The following is a description of a gene set: The series of molecular signals initiated by an extracellular ligand binding to a transforming growth factor beta receptor on the surface of a target cell, and ending with the regulation of a downstream cellular process, e.g. transcription. Mouse Gene Set: GOBP_TRANSFORMING_GROWTH_FACTOR_BETA_RECEPTOR_SIGNALING_PATHWAY species: Mus musculus, and this is the list of marker genes: Npnt, Peg10, Ptk2, Mir145b, Ero1a, Rnf111, Bcl9l, Tgfbr1, Bambi, Mstn, Skil, Trim33, Smad2, Htra3, Selenon, Cited1, Lrrc32, Snx1, Sox11, Smurf1, Skor2, Ppara (peroxisome proliferator activated receptor alpha), Onecut1, Pin1, Slc2a10, Itgb5, Zmiz1, Foxh1, Cldn5, Arrb2, Dnm2, Wfikkn2, Cidea, Pin1rt1, Fos, Acvrl1, Adissp, Lats2, Twsg1, Zfp451, Zyx, Tnrc6c, Fbn1, Gdf2, Parp1, Lats1, Dand5, Fbn2, Sirt1, Map3k1, Ryr1, Ltbp1, Sap130, Cdh3, Snw1, Mir143, Pxn, Ing2, Snx6, Brms1, Tgfb1i1, Arap1, Gcnt2, Pbld1, Amhr2, Wfikkn1, Nrep, Myocd, Lox, Emilin1, Col1a2, Fermt2, Furin, Bmp2, Hspa5, Adam17, Stk11, Smad5, Ovol2, Bmpr1a, Stat3, Hpgd, Strap, Htra1, Pml, Cd109, Cdkn2b, Got1, Rbbp7 (retinoblastoma binding protein 7, chromatin remodeling factor), Aspn, Eng, Pmepa1, Mir145a (microRNA 145a), Src (NCBI Gene Id 99351), Lrp1, Smad7, Lemd3, Crebbp, Tab1 (TGF-beta activated kinase 1/MAP3K7 binding protein 1), Il17rd, Cav2, Tet1, Ltbp3, Ptprk, Sdcbp (syndecan binding protein), Fut8, Stub1 (NCBI Gene Id 80391), Itgb1, Chst11, Cilp, Adamtsl2, Nlk, Arid4a, Zbtb7a, Tgfb3, Tsc22d1, Cripto, Col3a1, Bmpr1b, Suds3, Spry1, Hsp90ab1, Cdh5, Dusp22, Fermt1, Ints9, Hipk2 (homeodomain interacting protein kinase 2), Nrros, Vasn, Map3k7, Zeb2 (zinc finger E-box binding homeobox 2), Creb1, Tgfb2, Gdf15, Dcp1a, Spred2, Spred3, Spi1, Prdm16, Ldlrad4, Nkx2-1, Ndp, Pbld2, Men1, Rbbp4, Zfyve9 (NCBI Gene Id 381539), Ltbp4, Sinhcaf, Ppm1a, Spred1, Fam89b, Ing1, Cdkn1c, Zeb1, Adam9, Bmp8a (bone morphogenetic protein 8a), Itga3, Jun, Arid4b, Gdnf, Glg1, Smad3, Zfp703, Snx25, Cited2, Ski, Folr1, Tgfbr3, Cav3, Dab2, Acvr1, Itgb8, Nepn, Itga8, Smad1, Eid2, Ep300 (NCBI Gene Id 328572), Il17f (NCBI Gene Id 96930), Acvr1c, Itgb6, Xbp1, Fkbp1a (NCBI Gene Id 14225), Bmp8b, Ccl2, Pparg, Gipc1, Usp15, Sap30l, Appl2, Smad6, Spry2, Fshb, Lrg1, Lgals9, Pals1, Brms1l, Sin3a, Smurf2, Wnt1, Ogt, Smad4, Thbs1, Axin1, Sap30, Lpxn, Usp9x, Hdac2, Veph1, Pdpk1 (3-phosphoinositide dependent protein kinase 1), Rasl11b, Appl1, Tgfbr2, Tgfb1, Trp53 (transformation related protein 53), Onecut2, Smad9, Hdac1, Flcn, Tgfbr3l, Nodal